The following is a description of a gene set: studied in species Homo sapiens Missing or malformed long bones of the extremities with the distal parts (such as hands and/or feet) connected to the variably shortened or even absent extremity, leading to a flipper-like appearance, as opposed to other forms of limb malformations were either the hole limb is missing (such as amelia), or the distal part of a limb is absent (peromelia). Human Gene Set: HP_PHOCOMELIA Phocomelia, and this is the list of marker genes: LBR, TBX5, LMBR1, NIPBL (NIPBL cohesin loading factor), ESCO2, SF3B4, WNT7A, RBM8A